The following is a description of a gene set: from publication Ng SY, Yoshida T, Zhang J, Georgopoulos K (PMID 19345118) Human Gene Set: GSE15330_WT_VS_IKAROS_KO_HSC_DN Regulation of lineage potential and transcriptional priming by Ikaros. New insight is provided into a bivalent regulation of lineage priming in the HSC and its lympho-myeloid restricted progeny the LMPP by the lymphoid lineage-determining factor Ikaros Whereas Ikaros is responsible for the activation of a cascade of lymphoid expression programs and for the establishment of lymphoid potential from the HSC to the LMPP it is also responsible for the repression of stem cell and erythroid genetic programs that are incompatible with further lineage restrictions emanating from the LMPP Genes down-regulated in hematopoietic stem cells: wildtype versus IKZF1 knockout. species: Homo sapiens, and this is the list of marker genes: GTF2IRD1, LAIR1, PLCG2, NAB1, DGAT1, NCBP3, PYCR1, PPP1CC, C2CD2L, RPL24, SLC25A15, SEMA4D, ELOVL1, CDC42EP3, EIF2B2, GLB1, SF3A2, HIPK2, PITPNB (phosphatidylinositol transfer protein beta), INO80C, PNKP, FAM151A, CDK16, ST3GAL4, ZFAND2B, EFHD2, SLC6A1, CRK, CAMKK1, KLF13, ANXA4, NR1D2, CORO1C, INHA, SYNE1, CAPN15, IFFO2, KRT1, ATP6AP2, PYY, MYO5A, SBK1, TM9SF2, PIMREG, CREB3L2, SMAD4, CDK5, ANAPC16, LRRC8C, PEA15, ANKH, RRBP1, SLC4A2, CARD19, SIGIRR, MGST3, CCNC, RNH1, STK17B, KIFAP3, DNAJA4, SLC12A7, PAGR1, ZDHHC20 (NCBI Gene Id 353177), ANKS1A, ESRRA, CDKN1B, PAFAH1B1, CTDP1, WASF2, GSTK1, ABCG1 (NCBI Gene Id 9619), OAF, ME2, TBCD, MTMR6, DYNC1H1, KDELR1, CASKIN2, DENND4B, B4GALT7, GRIA4, SMAP2, TLE5, KLB, TMEM167A, IRF4 (interferon regulatory factor 4), CERK, IMPDH1, CLTC, MYOF, PAFAH1B2, MYBL2, SSX2IP, COMMD4, TPSB2, CHD7, SMPD2, SERPINF1, CLIC1, FTH1, SPC25, ETV6, CXCL10, RAB20, STAT3, TRPC4AP, RDM1, PANX1, LBP, UBTD1, SEC14L1, CCDC92, DAO, AURKB, PC, SNX2, CCDC88C, ZC3H12C, SHROOM3, LUC7L2, SOX5, ITGB3, THAP12, GDI2, PLA2G15, SEPTIN10, LRRC8A, LSM14A, SEC24D, PREB, MFSD10, CAPN1, ATL2, TMED10, SVBP, RPL5, JAK3, DNM2, CTSA, SLC15A3, FAM89B (family with sequence similarity 89 member B), UBE2B, RIOX2, CXCR6, NOCT, NLGN2, GNG2, GLUD1, C19orf25, KAT2B, SMTN, TAB2, SLC44A1, GMFG (NCBI Gene Id 9535), TMEM199, EHD4, CDC6 (cell division cycle 6), GJA1, RACGAP1, IL9, BIK, ULK1, IER5, MXD3, ZBTB45, CAPN2, ITSN2, KIF5C, SNX14, AKR1C3, ATP6V1D, ID1, DNAJB6, ARPC1B, DCTN5, NCKAP1, KLK4, LDLRAD4, RRAS, RAP1B, NT5C, MBD1, BEX3 (brain expressed X-linked 3), PLEKHA2, CRIPT, VPS35, ATL3, ARFGAP1, CABLES2, FAAP20 (FA core complex associated protein 20), FBXO21, NCBP2AS2, UBE2Z, SAP30 (Sin3A associated protein 30), HDAC1, SLC33A1, TWF2, IL17RA